Given this list of marker genes Tagap, Elapor1, Nsd3, Akr1c14, Lrrc7, Armc1 (armadillo repeat containing 1), E2f6, Plxnc1, Ift122, Klhl20, Spo11, Ly6e, Akr1b1, Ttc39b, Ywhaz, Lipa (lysosomal acid lipase A), Ptpru, Arhgap21, Vps13d, Frs2, Ube2e2, Lrrc59, Prkag2, Slc17a2, Casp8ap2, Nr2e1, Itgb6, Cacnb2, Spag9, Polr3e, Tex14, Josd2, Pabir2, Lpcat4, Rab27b, Extl2, Mindy2, Lins1, Zfp281, Myc, Elmod1, Prune2, Dgka, Enox2, Kdm4b, Kcnk4, Cacna1d, Hnrnpll, Mpc2, Lyn, Ergic1, Rab39b, Mef2c, Polr2k, Ptpn2, Caprin2, Bche, Arhgef28, Macir, Krt26, Tfcp2, Bmerb1, Sptbn1, Srrm4 (NCBI Gene Id 78602), Cdc42se1, Fitm2, Slc26a9, Dcaf1, Zeb2, Tnrc6a, Sh3bgrl, Hoxd1, Il36g, Tagap1, Socs3, Lmbr1l, Rit2, Ttn, Kcna2, Hdhd5, Psmd5, Mid1, Cep97, Tppp3, Calm2, Meis2, here is a description of the gene set: Genes predicted to be targets of miRBase v22 microRNA mmu_miR_6974_5p in miRDB v6.0 with MirTarget v4 prediction scores > 80 (high confidence targets). studied in species Mus musculus Mouse Gene Set: MIR_6974_5P from publication Chen Y, Wang X (PMID 31504780)